Given this list of marker genes CCNI, PSG1 (pregnancy specific beta-1-glycoprotein 1), CD302, ACTR1B, CNN3, DRD2, TANK, SAFB, LAMA2, GDI1, CUX1, FAS, MAPT, FAP, SLC2A4, LRP1, DEFA6, STX4, ELANE, APP, RYK, GJB1, TCF12, ARCN1, BCL6, RGS6, KLHDC3, EMP3, DHX38, MTMR11, DES, CPA3, CLEC3B, PDK4, KLRK1, ZKSCAN3, TUBA1A, PHKG1, MYH9, FABP5, RNF113A, SCRIB, KL, FLNA, SPTAN1, AP2S1, COL1A2, UPP1, PAFAH1B3, ATP2B2 (NCBI Gene Id 491), VAT1, TOB1, ENG, NR4A3, RASSF2, CYB5R3, RBP1, S100A4, HSPG2, XGY2, MYH10, SOX15, HSPA6, GNL1, CCL13, ACTB, TGFBR2, ITGB8, LUM, KRT12, IER2, RASA2, CHKB, LIMK1, COL1A1, IGFBP4, CALB2, S100A11, ZNF211, CALB1, COL3A1, MYCL (MYCL proto-oncogene, bHLH transcription factor), FGL1, COL6A3, SNTA1, HCLS1, GAS1, PLAU, SLC1A1, FN1, C1QB, CCR5, NAGLU, CKAP4, here is a description of the gene set: Upregulated in the vastus lateralis muscle of middle aged rhesus monkeys subjected to caloric restriction since young adulthood vs age matched controls from publication Kayo T, Allison DB, Weindruch R, Prolla TA (PMID 11309484) studied in species Homo sapiens Human Gene Set: KAYO_CALORIE_RESTRICTION_MUSCLE_UP In laboratory rodents, caloric restriction (CR) retards several age-dependent physiological and biochemical changes in skeletal muscle, including increased steady-state levels of oxidative damage to lipids, DNA, and proteins. We have previously used high-density oligonucleotide arrays to show that CR can prevent or delay most of the major age-related transcriptional alterations in the gastrocnemius muscle of C57BL/6 mice. Here we report the effects of aging and adult-onset CR on the gene expression profile of genes in the vastus lateralis muscle from rhesus monkeys. Gene expression analysis of aged rhesus monkeys (mean age of 26 years) was compared with that of young animals (mean age of 8 years). Aging resulted in a selective up-regulation of transcripts involved in inflammation and oxidative stress, and a down-regulation of genes involved in mitochondrial electron transport and oxidative phosphorylation. Middle-aged monkeys (mean age of 20 years) subjected to CR since early adulthood (mean age of 11 years) were studied to determine the gene expression profile induced by CR. CR resulted in an up-regulation of cytoskeletal protein-encoding genes, and also a decrease in the expression of genes involved in mitochondrial bioenergetics. Surprisingly, we did not observe any evidence for an inhibitory effect of adult-onset CR on age-related changes in gene expression. These results indicate that the induction of an oxidative stress-induced transcriptional response may be a common feature of aging in skeletal muscle of rodents and primates, but the extent to which CR modifies these responses may be species-specific.